Given this list of marker genes Creb5, Src, Ociad2, Vangl2, Ogfod1, Ppp1r26, Myadm, Tmcc3, Zbtb2, Cdc25b, Sh3kbp1, Add2, Eif4g3, Entpd5, Nrp2, Gpr88, Kctd12, Larp1, G3bp2, Gucy1a1, Pak3, Sox5, Mef2c, Akap5, Fryl, Gtf2i, Pik3ca, Baz2a, Cdk19, Tmem151b, Wbp1l, Zfp185, Kdm4a, Csmd2, Fam53c, Capzb, Ralgps1, Fam168b, Dnlz, Wdr26, Lypd1, Tph1, Tspan5, Dlgap4, Fosb, Tmem178b, Sema6d, Ndrg2, Inka2, Slc36a1, Afg3l1, Pik3cd, Skil, Amph, Rapgef1, Syt17, Egr3, Atosb, Nacc2, Usf3, Zbtb42, Zbtb34, Fus, Pfkfb3, Igdcc4, Ets1, Mapk14, Osbpl5, Tbcel, Bend4, Synpo2l, Prdm16, Dclk1, Il15ra, Lpar1, Trip12, Frrs1l, Arrb1, Slc25a37, Zfp408, Smim10l2a, Pcgf2, Tmod2, Knop1, Mecom, Fnbp1, Hlcs, Dph6, Phka1, Zfp811, Sypl1, Clasp1, Fam219a, Tcf24 (NCBI Gene Id 100045893), Trp53bp1, Ndrg4, Akap8, Hapln3, Haus2, Cdc42bpa, Trappc9, Atg16l1, Tent5c, Sin3a, Cytip, Gpr83, Itgam (NCBI Gene Id 16409), Tns1, Itsn1, Dcaf17, Tmem8b, Arhgef9, Tbl1xr1, Piga, Mtus1 (mitochondrial tumor suppressor 1), Acot3, Arl5b, Fbxo41, Sema4f, Tent4b, E2f1, Gsk3b, Tmem121b, Rnft2, Il21r, Greb1, Ino80d, Bcl2l11, Rab3c, Apol8, Nedd4l, Ldb3, Pak6 (NCBI Gene Id 214230), Diaph2, Yipf6, Prn, Pitpnm3, Hdac7, Adamts4, Trpc6, Mxi1, Gmeb1, Clmn, Tmem201, Papola, Slc19a2, Draxin, Parp11, Zfp467, Nras, Kif3c, Mapk1ip1l (mitogen-activated protein kinase 1 interacting protein 1-like), Prnd, Llgl1, Eya1, Ikbkb, Zfx, Nfx1, Pgbd1, Rnasel, Mgat4a, Mettl14, Ak1, Sema4c, Nap1l4, Rangap1, Traf3, Cops7b, Slc25a51, Slc1a4, Rragd, Il1rl1, Etv3, Madd, here is a description of the gene set: Mouse Gene Set: XIE_TRASTUZUMAB_CARDIOTOXICITY_MMU_MIR_669C_3P_GENES Abstract: Trastuzumab-induced cardiotoxicity (TIC) is a common and serious disease with abnormal cardiac function. Accumulating evidence has indicated certain non-coding RNAs (ncRNAs), functioning as competing endogenous RNAs (ceRNAs), impacting the progression of cardiovascular diseases. Nonetheless, the specific involvement of ncRNA-mediated ceRNA regulatory mechanisms in TIC remains elusive. The present research aims to comprehensively investigate changes in the expressions of all ncRNA using whole-transcriptome RNA sequencing. The sequencing analysis unveiled significant dysregulation, identifying a total of 43 circular RNAs (circRNAs), 270 long noncoding RNAs (lncRNAs), 12 microRNAs (miRNAs), and 4131 mRNAs in trastuzumab-treated mouse hearts. Subsequently, circRNA-based ceRNA networks consisting of 82 nodes and 91 edges, as well as lncRNA-based ceRNA networks comprising 111 nodes and 112 edges, were constructed. Using the CytoNCA plugin, pivotal genes - miR-31-5p and miR-644-5p - were identified within these networks, exhibiting potential relevance in TIC treatment. Additionally, KEGG and GO analyses were conducted to explore the functional pathways associated with the genes within the ceRNA networks. The outcomes of the predicted ceRNAs and bioinformatics analyses elucidated the plausible involvement of ncRNAs in TIC pathogenesis. This insight contributes to a better understanding of underlying mechanisms and aids in identifying promising targets for effective prevention and treatment strategies. studied in species Mus musculus from publication Xie S, Zhou N, Su N, Xiao Z, Wei S, Yang Y, Liu J, Li W, Zhang B (PMID 38577019)